The following is a description of a gene set: Genes down-regulated in CD4 T cells: TGFB1 versus TGFB1 and progesterone. We examined the global gene expression pattern of T cells regulated by progesterone to gain further insights into the regulatory mechanisms of progesterone. We found 325-347 cord blood T cell genes up or down-regulated by P4 in the presence or absence of exogenous TGFb1. Peripheral blood T cells were relatively unresponsive with only 30-genes regulated by P4. IL-6 receptor (IL-6R) expression was greatly down-regulated by progesterone in cord blood, but not PB, T cells. Overall, these differences in gene expression are consistent with the differential responses of cord blood and peripheral blood T cells to progesterone. To gain insights into the differences of progesterone and control dendritic cells, we performed a microarray study and found ~genes regulated by progesterone in dendritic cells. The gene expression information suggests that progesterone has the potential to alter dendritic cell responses to cytokines, chemokine production, and migration which in combination would control T cell differentiation. Human Gene Set: GSE22025_TGFB1_VS_TGFB1_AND_PROGESTERONE_TREATED_CD4_TCELL_DN from publication Lee JH, Ulrich B, Cho J, Park J, Kim CH (PMID 21768398) studied in species Homo sapiens, and this is the list of marker genes: CD6, PKD1, KRT35, AGPAT1, UAP1, SPINT3, POMC, IL6, EYA1, PLP2, CKMT2, RREB1, HLTF, SOCS7, GATA6, MUC5AC, FURIN, SGCG, ADAM19, CD79A, MAST1, IDS, ACTG1, VAV1, BST1 (NCBI Gene Id 683), CEACAM6, RRP12, MINPP1, GPX4 (glutathione peroxidase 4), ACSL1, CTRC, LAPTM5, NMB, ENO2, HMG20B (NCBI Gene Id 10448), CDK5R2, ADCY8, SPDEF, PCYT1B, DCBLD2, SPARC, TBX1, IRS4, GJC1, HSPA12A, CXCR5, PAMR1, HOXA4, DYRK3, COL6A1, ZNF460, NGF (nerve growth factor), DENND3, IAPP, MMP12, EIF3A, SLC6A12, PRDX1, ATF3, PAIP2B, SHOX2, ARHGEF1, GYS1, NDP, DNAJC6, JUN, FMOD, SOX4, NR0B1, CEBPG, PCDH7, IRX5, ITGA1, PDHA2, REEP2, CDC25C, TNFSF14, TP53I11, MCF2, FAM32A, ZW10, NID2 (NCBI Gene Id 95183), CCL20, THBS2, MARCHF3, TESK1, PPIP5K1, OR2H1, FLII, GRIK2, NR5A2, ATP1B1, RBM14, H2AX, ABCC3, GNMT, C1QL1, PHLPP2, CTSL, OSBPL8, SUSD6, COL4A1, COL6A3, MLH1, ONECUT2, PICK1, HTR2C, CHERP, RPL38, TPBG, UBTF, MKNK1, DKFZP434A062, GNB2, MLLT3, BMPR2, MAP3K13, HS2ST1, MPZL1, GSTO1, RAD50 (RAD50 double strand break repair protein), NINL, WWC1, PDXK, SLC22A14, CDK17, SLC16A1, C8G, KCNC3, BRDT, SPINK5, DSCR4, RPH3A, CRISP2, NR4A2, NCOR2, ST3GAL1, GOT2, HOXA1, CDSN, CA7, PCDHGA12, SAA4, BASP1, WDR1, ADRA1B, CABIN1, DSG1, LEFTY1, RGS16, TNFSF11, TUBA4A, ID3, PGAP4, TGFB1, MAP2K3, FCGR3B, EIF3B, WNT1, DIAPH2, LAPTM4B, GJA5, DZIP1, CLDN3, REL, NEFM, UBE2K, STK38L, LIF, GPM6A, SLAMF1, SZT2, CD44, SLC10A3, IGFBP4, HYAL1, HBEGF, FGFR4, ELANE, MISP, TNFRSF25, TNK2, OPCML, CALML3, VGLL4, SMURF1, TRIM15, REG1CP, CENPF, PPM1B, PTPN22, FGG, ZIC1, SEMA6C, PLCB1, NPY2R, GEM, CAMSAP2, NECTIN3